The following is a description of a gene set: studied in species Homo sapiens Human Gene Set: SEITZ_NEOPLASTIC_TRANSFORMATION_BY_8P_DELETION_UP Genes up-regulated in CT60/4 cells (breast cancer reverted to normal by transfer of chromosome 8p region) vs parental MDA-MB-231 cells (deleted chromosome 8p). Several investigations have supposed that tumor suppressor genes might be located on human chromosome 8. We used microcell-mediated transfer of chromosome 8 into MDA-MB-231 breast cancer cells and generated independent hybrids with strongly reduced tumorigenic potential. Loss of the transferred chromosome results in reappearance of the malignant phenotype. Expression analysis identified a set of genes (CT8-ps) differentially expressed in microcell hybrids as compared to the tumorigenic MDA-MB-231 and rerevertant cells. Of these, 44.9% are differentially expressed in human breast tumors. The expression pattern of CT8-ps was associated with prognostic factors such as tumor size and grading as well as loss of heterozygosity at the short arm of chromosome 8. We identified CT8-ps networks suggesting that these genes act cooperatively to cause reversion of tumorigenicity in MDA-MB-231 cells. Our findings provide a conceptual basis and experimental system to identify and evaluate genes and gene networks involved in the development and/or progression of breast cancer. from publication Seitz S, Frege R, Jacobsen A, Weimer J, Arnold W, von Haefen C, Niederacher D, Schmutzler R, Arnold N, Scherneck S (PMID 15580292), and this is the list of marker genes: COL1A2, ABCG2, IFI27, PTN, CX3CL1, IFIT1, IFI44L, BCHE, MAPRE2, SEMA3A, ZC3HAV1, GPRC5A, MX1, CXCL10, ZFP36L2, TIMP3, CCN3, UGT1A10, CRISPLD2, SORL1, CD24P2 (NCBI Gene Id 936), BMP4, ISG15, OAS2, TMEM50A, SLIT2, TFF1, IDO1, OASL, SPOCK1, SAMD9, IGFBP6, IFIH1, TENT5A, CLU, SORD, IFIT2, NR2F1 (nuclear receptor subfamily 2 group F member 1), NMU, ID2, EFNB2, KLF4, RIGI, GBP1, PNP, MAGEA3, CCNE2, CXCL11, DDX60, HPSE, HS3ST1, CH25H, PLAAT4, PTGER4, TLR4, MX2, HERC5, PDLIM5, CD24, MALL, CCL5, UGT1A8, ALDH1A3, IFIT3, PRR16, NDP, ISG20, ADAM28, DAAM1, OAS1, TMEM70, EVI2B, HERC6, LIPG, IFI44